Given this list of marker genes FAM199X, PTS, FUBP1, UFL1, AMBRA1, TBX6, RELCH, SLC25A28 (solute carrier family 25 member 28), SUPT4H1, MMS19, RBM18, PGGT1B, OLFM1, POLR3K, PLEKHM3, TM9SF2, ZNF629, TPCN2, RABAC1, MYO1F, BCAT2, PRKAB1, CCNY, PLS3, EIF4A2, SPATA6, ZBTB20, PID1, ACBD3, SHC4, ACP2, CHD2, HNRNPC, NAT1, FGD4, NDOR1, HOXA10, CCDC91, BPIFA2, RPLP2, ASB3, FBXL3, YIF1A (NCBI Gene Id 10897), ERRFI1, ZNF260, CLNS1A, RXFP2, TMEM234, WDFY2, TAPT1, BCAP31, SLC15A2, ZNF787, RBM48 (RNA binding motif protein 48), NOP2, RICTOR, CAPNS1, EHF, WARS2 (tryptophanyl tRNA synthetase 2, mitochondrial), SMCO1, EFCAB14, DYNC1I2, DENND11, KPNA1, DCLRE1C, BMAL1, PPIE, MYLIP, MEP1A, CNPY3, ZBTB45, ATRX, EXO5, OXR1, RPIA, TMEM143, MAST4, HLA-DRB1, SMPD2, BRMS1, EHBP1 (EH domain binding protein 1), XPR1, FAM98B, B4GALT1, NT5DC1, UAP1L1, HMBOX1 (homeobox containing 1), YWHAH, DNAJC10, ZNF236, SLC35A4, TRMT10B, TUG1, SLC4A7, ZDHHC24, ERP44, PPIL3, ZFC3H1, GNPNAT1, ADD1, RIMOC1, TRIAP1, FARP2, UVSSA, RPL24, U2SURP, RCE1, USP8, MMP9, ZNF287, RPS7, IL9R, SPICE1, ATOSA, CKLF, BIN3, D2HGDH, PDK3, HEATR5A, DDX50, LAMC1 (laminin subunit gamma 1), GTF2A2, SPMIP8, SP1, RSBN1, RBMS2, ATP2B3, CSNK1G2, DNAJC21, ZMYND11, PIGO, EXOC5, ALG1, CSTF2T, MAPK14, MFSD9, ZMYM2, USP42, NONO, FRS2, RGS19, SPATA1, SLMAP, AGPAT5, SIAE (sialic acid acetylesterase), RABEP1, SLC30A6, BAZ1A (NCBI Gene Id 25985), KAT5, NFRKB, LAMTOR4, TIMMDC1, RO60, RALGPS2, MED13L, SEL1L3, PSMG1 (NCBI Gene Id 8624), STIP1, RAB8B, RHOT1, HUWE1, TOMM40, RAP2C, TCTA, BAZ2B, PLEK, CYRIB, PLCG1, PLEKHN1, ZHX1, SEPTIN2, FBXL6, CNN2, UBN2, FAM98C, NKIRAS1, CNTN4, GRWD1, LPIN1, ATPAF1, SLC32A1, ACP6, CDKN2A, MKLN1, ZBTB33, NOP16, TFRC, CD38, ZFP90, DYNLT1, SFT2D3, NDUFAF4, B4GALNT2, C19orf48P, ABCG2, WDCP, AK5, KRIT1, GSTK1, LCP2, here is a description of the gene set: Th1 and Th2 cells arise from a common precursor cell in response to triggering through the TCR and cytokine receptors for IL-12 or IL-4. This leads to activation of complex signaling pathways, which are not known in detail. Disturbances in the balance between type 1 and type 2 responses can lead to certain immune-mediated diseases. Thus, it is important to understand how Th1 and Th2 cells are generated. To clarify the mechanisms as to how IL-12 and IL-4 induce Th1 and Th2 differentiation and how TGF-beta can inhibit this process, we have used oligonucleotide arrays to examine the early polarization of Th1 and Th2 cells in the presence and absence of TGF-beta after 0, 2, 6 and 48 hours of polarization. Genes down-regulated in CD4 T cells: untreated (0h) versus activated by anti-CD3 and anti-CD28 and then stimulated by TGFB1 and IL-12 (48h). Human Gene Set: GSE2770_UNTREATED_VS_TGFB_AND_IL12_TREATED_ACT_CD4_TCELL_48H_DN species: Homo sapiens from publication Lund R, Aittokallio T, Nevalainen O, Lahesmaa R (PMID 14607935)